The following is a description of a gene set: Human Gene Set: HP_ABNORMAL_PLACENTA_MORPHOLOGY species: Homo sapiens Abnormal placenta morphology An abnormality of the placenta, the organ that connects the developing fetus to the uterine wall to enable nutrient uptake, waste elimination, and gas exchange., and this is the list of marker genes: FANCF, KIT, CFH (NCBI Gene Id 3076), ZMPSTE24 (zinc metallopeptidase STE24), STOX1, GLB1, LMNA, FGFR3, MDM2, CORIN, MKS1, DLK1, SPTBN1, CDKN2A, IGF2, PLAGL1, BCL10, MUSK (muscle associated receptor tyrosine kinase), MEG3, CDKN1C, TP53, PHGDH, HYMAI, FLT1, HELLPAR, IGF1, SKIC3, KCNQ1, CFI, HSPG2, KCNQ1OT1, STK11, LBR, RTL1, PLAG1, HMGA2, CD46, CHEK2